Given this list of marker genes Gaa, Tnnc1, Adrb2, Selenon, Ddit3, here is a description of the gene set: Mouse Gene Set: GOBP_DIAPHRAGM_CONTRACTION species: Mus musculus A process in which force is generated within involuntary skeletal muscle tissue, resulting in a change in muscle geometry. This process occurs in the diaphragm. Force generation involves a chemo-mechanical energy conversion step that is carried out by the actin/myosin complex activity, which generates force through ATP hydrolysis. The diaphragm is a striated muscle that is necessary for the process of respiratory gaseous exchange.